Given this list of marker genes HES7 (NCBI Gene Id 84667), LAGE3, TRAPPC2, RRM2B, COL9A1, WDR73, MT-ATP8, RIPPLY2, SMAD2, PLCB3, XYLT2, MAP3K7, TNFRSF11B, WDR4, ACP5, PPP1CB, LFNG, MATN3, HGD, MESP2, SLC26A2, ANKH, CHST3, TP53RK, SMAD3, DLL3 (NCBI Gene Id 10683), FN1, TPRKB, YRDC, SHOC2, TMEM53, MT-TL1, NUP133, LMNA, NT5E, LTBP3, TBX1 (T-box transcription factor 1), OSGEP, COL2A1, NUP107, TRPV4 (transient receptor potential cation channel subfamily V member 4), RNU4ATAC, EXTL3 (exostosin like glycosyltransferase 3), HOXD13, GON7, BPNT2, here is a description of the gene set: Any structural abnormality of the intervertebral disk. Human Gene Set: HP_ABNORMAL_INTERVERTEBRAL_DISK_MORPHOLOGY studied in species Homo sapiens Abnormal intervertebral disk morphology